The following is a description of a gene set: Genes predicted to be targets of miRBase v22 microRNA mmu_miR_149_3p in miRDB v6.0 with MirTarget v4 prediction scores > 80 (high confidence targets). from publication Chen Y, Wang X (PMID 31504780) studied in species Mus musculus Mouse Gene Set: MIR_149_3P, and this is the list of marker genes: Rpl31, Aspg, St3gal1, Sash1, Klc2, Tlcd5, Emc4, Rin1, Klhl9, Slc7a1, Mylk4, Slc1a3, Selenom, AU018091, Xylb, Mpig6b, Rassf2, Nova2, Psd4, Slc16a14, Wdtc1, Nos2, Aoc3, Dmtn, Dlk1, Msl1, Prdm2, Zfhx3, Shisa7 (NCBI Gene Id 232813), Cts8, Ptpn3, Drc7, Kcnj10, Rab11fip5, Ankrd63, Cyyr1, Aif1l, Sf3b4, Prcp, Ubqln2, Lhpp, Pianp, Uqcrq (ubiquinol-cytochrome c reductase, complex III subunit VII), Slc7a8, Asb15, Galnt17 (polypeptide N-acetylgalactosaminyltransferase 17), Clec16a (NCBI Gene Id 74374), Zmat3, Eif4e1b, Ttc28, Ranbp10, Acad9, Ccdc171, Gpr173, Arhgdia, Ap1s3, Rnf150, Plxna4, Lpar2, Mea1 (NCBI Gene Id 17256), Fign, Hoxc10, Arnt2, Chd3, Nes, Slc22a23, Trp53inp2, Baz2a, Pkd1, Dnal1, Tfap2a, Gnat1, Zfp59, Mospd3, Smap2, Idi2, Lrrc59, Kcne1, Samhd1, Morc4, Dop1a, Zfp444, Bzw1, Dhtkd1, Fosl2, Zfp92, Lrrtm1, Nectin1, Pakap, Astn2, C2cd2l, Klk4, Klhl4 (kelch-like 4, NCBI Gene Id 237010), Mon1b, Htt, Rnf152, Ipmk, Eya3, Mtcl2, Bhlhe40, Ap2a1, Kics2, Leng8, Rftn2, Bahd1, Ap1g1, Pak1ip1, Erv3, Sema6a, Itga8, Tspan9, Bard1, Smarcc1, Tmem175, Rnd1, Epas1, Slc8a2, Mxd4